Given this list of marker genes HNRNPU, TTBK2, ABL1, DVL1, CHAMP1, MAPRE2, KIF20B, ABHD17C, MAPRE3, MAPRE1, DIAPH1, GAS2L1, GAS2L2, MID2, ABHD17A, MAP1A, ABHD17B, CRIPT, MID1, here is a description of the gene set: species: Homo sapiens A process in which a protein is transported to, or maintained at, a microtubule. Human Gene Set: GOBP_PROTEIN_LOCALIZATION_TO_MICROTUBULE